The following is a description of a gene set: Human Gene Set: HP_ABNORMAL_DENTIN_MORPHOLOGY Any abnormality of dentin. Abnormal dentin morphology studied in species Homo sapiens, and this is the list of marker genes: SERPINH1, COL1A1, DSPP, SPARC, SERPINF1, CCDC134, P3H1, STAT3, SP7, FKBP10, ACP4, AMELX, COL1A2, MBTPS2, CDH11, P4HB, B3GALT6, TRIP11, MIA3, SEC24D, ZNF469, IFITM5, CRTAP, PHEX, BMP1, PPIB, TMEM38B